Given this list of marker genes RYR3, OR2S2, SLC20A1, HUWE1, LAMA5, MBTPS1, SCGB1D2, CD244, GLRX, PCSK1N, RNF208, KIAA0513 (KIAA0513), RTEL1 (regulator of telomere elongation helicase 1), SERBP1, MMUT, CEP57, SLC25A11, RRM1, KDM4C, POLR2B, UFC1, S100A6, OCEL1 (NCBI Gene Id 79629), HSD17B1, DNAJC10, TBP, ZNF665, TRIM21, ZNF23, POLA1, ULK4, RBM26, ATRN, ELOVL5, FNBP4, MMP11, TTLL7, DPH5, ATP6V1H, C1orf50, ZKSCAN3, ATPAF2 (ATP synthase mitochondrial F1 complex assembly factor 2), ACTL7A, NFATC3, CCDC9, DOLPP1 (NCBI Gene Id 89888), FBXW12, EXOC1, MID2, REEP1, PBXIP1, PIK3CB, CPQ, PCID2, MLEC, ZKSCAN5, HNRNPL, TXNDC9, RPS12, NDUFS2 (NADH:ubiquinone oxidoreductase core subunit S2), ELMO1, CD1C, SEC14L5, INSL5, SLC22A5, POLR2F, PCF11, OSBPL8, KYAT1, RPS25, DCLK1, RNF130, RPL36AL, MFHAS1, TXNL1 (NCBI Gene Id 9352), WNT7A, TSR3, STAP1, MIPEP, KIR2DS3 (killer cell immunoglobulin like receptor, two Ig domains and short cytoplasmic tail 3), MAPKAPK3 (MAPK activated protein kinase 3), NFS1, MSRA (NCBI Gene Id 4482), EVI2B, TNFRSF8, SLC39A4, RPS6, TREX2, DESI2, TSC2 (NCBI Gene Id 7249), GBF1, DNAJC8, TNPO3, ZIC1, VAMP4, PADI3, STAT6, PPIH, DMPK, GPR52, TMCO3 (transmembrane and coiled-coil domains 3), HIBCH, ZNF292, SNRNP27, EIF3F, PXDN, MYO15B, STK38, TMEM14B, CSNK1G1, BAG4, RPL12, ARHGEF3, MPI, AIRIM, NAP1L2, ELP4, BRF2, BTF3, ZBTB5, SMIM7, EFCAB14, KATNA1, CREG1, CCDC88A, EIF3E, MCF2, CHRNB3, ZNF208, SAP18, HDAC1, DIP2C, VPS26A, GMPR2, CADM1, RGP1, PML, MORN1, DDX46, LRBA, SLC33A1, TM9SF3, KIR2DS2, CD53 (CD53 molecule), PXN, QRSL1 (glutaminyl-tRNA amidotransferase subunit QRSL1), GHSR, AMACR, ATP6V0E1, IQSEC1, SRD5A1, MAU2, IQGAP1, GLI3, IL6ST, PYGL, RC3H2, FYCO1, ATG3, CAPN3, RPS14, DNAJB14, RNF13, DTWD1, CTNNBL1, RPL23, MOSPD1, GNG12, KLHL24 (NCBI Gene Id 79965), SYT5, CTSO, TGFA, TRPV4, MICU1, DVL3, IRF9, MAP2K1, NCK2, METTL5, PANK4, RPS10P5, SLC25A13 (solute carrier family 25 member 13), REEP5, PHF10, SEC14L1, API5, SRSF11, TRNAU1AP, ANKRD17, CIAPIN1, CDYL, SLC2A10, GLRB, ZC3H3, SMARCA4, SACS, ATP5PO (NCBI Gene Id 539), TRIM66, RPL28, here is a description of the gene set: from publication Jeffrey KL, Brummer T, Rolph MS, Liu SM, Callejas NA, Grumont RJ, Gillieron C, Mackay F, Grey S, Camps M, Rommel C, Gerondakis SD, Mackay CR (PMID 16474395) Genes up-regulated in comparison of untreated mast cells versus mast cells treated with IgE at 2 h. Human Gene Set: GSE3982_CTRL_VS_IGE_STIM_MAST_CELL_UP species: Homo sapiens In the present study we used Affymetrix oligonucleotide microarrays to produce gene transcription profiles for the major leukocyte types in humans. This comprehensive dataset enabled us to not only establish which genes were expressed in each leukocyte type, but also which genes were expressed in each subset after activation. The used of a comprehensive dataset of gene profiles from all the major human leukocyte subsets enabled a novel and powerful means for identification of genes associated with single leukocyte subsets, or different immune paradigms.